The following is a description of a gene set: Calcitonin-like ligand receptors species: Homo sapiens Human Gene Set: REACTOME_CALCITONIN_LIKE_LIGAND_RECEPTORS, and this is the list of marker genes: RAMP2, CALCR, RAMP1, CALCRL, IAPP, RAMP3, CALCB, ADM, CALCA, ADM2